Given this list of marker genes Zc2hc1c, Kif26b, Slc16a2, Sting1, Lrrc14b, Pnp, Scimp (NCBI Gene Id 547221), Zbtb7c, Mss51, Kctd10, Dmd (NCBI Gene Id 93863), Timp3 (tissue inhibitor of metalloproteinase 3), Sidt2, Iqsec3, Hspb6, Mical2, Mid1ip1, Usp4, Ramp1, Srsf3, Slc4a5, Pbx1, Cdc27, Lin9, Cyp3a44, Adi1, Usp34, Zfp113, Zfp770, Zfp169, Nfatc3, Adora1, C1qtnf3, Fhip1b, Mindy2, Gk, Cnr1, Msmo1, Prrc2c, Dab2, Rcan1 (NCBI Gene Id 80500), Flrt2, Ufd1, Stt3b, Fgf7, Fbln5, Cttnbp2nl, Jade1, Alpi, Lair1, Sfrp1, Slco3a1, Aldh4a1, Slc16a10, Robo1, Prrc2b, Amotl2, Tgfbr1, Ide, Gm527, Tmem169, Fam219b, Crk, Meis2, Ell2, Arrb1, Gpr34, Zfp672, Ppfia1, Zmiz1, Dynll1, Calb1, Hoxa11, Mmp16, Gal3st2, Ccnj, Zbtb41, Stk35 (serine/threonine kinase 35), Map3k7, Rab1b, Gbx2, H6pd, Amotl1, Sema3a, Syndig1, Ift122, Slc25a34, Osgepl1, Egln3, here is a description of the gene set: Genes predicted to be targets of miRBase v22 microRNA mmu_miR_6938_3p in miRDB v6.0 with MirTarget v4 prediction scores > 80 (high confidence targets). species: Mus musculus from publication Chen Y, Wang X (PMID 31504780) Mouse Gene Set: MIR_6938_3P